Given this list of marker genes CDKN1B, CILP, HNRNPU, PDZK1, MAPK8IP3, KAT6A, PDE5A, DYNC2LI1, CA12, MRNIP, MAP2, CBLN1, GORAB, CACUL1, EPHA5, CCNT2, ZNF396, TMEM68, REEP3, USP6NL, ERG, PIAS1, CPEB2, HOXC6, KDM5B, SHROOM2, ERP27, CES3, BCL11B, SYTL2, KCTD9, TRA2B, LHX2, ACLY, CCNG2, SLC37A2 (NCBI Gene Id 219855), NOVA1, KCTD1, ANXA1, MTCL2, RTN1, MEOX2, AFF4, SRSF12, PALM2AKAP2, RAB4A, NXT2, APBB3, CIP2A, PTPRD, FNDC3B, PIK3CA, SLC25A36, SEPTIN11, ZNF75D, B4GALT4, BRD2, KIF5A, UNC13A, NFIA, CHCHD5, PPP1R16B, ARGLU1, DUSP6, CHD6, ARPP19, RUBCN, ZHX1, MRPL19, MACIR, GABPB1, MCMDC2, CC2D1B, FAM133B, STXBP1, TSG101, CYP2C9, GALNT7, RNF19A (ring finger protein 19A, RBR E3 ubiquitin protein ligase), PAXIP1, FAM13C (family with sequence similarity 13 member C), ZBTB24, STEAP2, CIAO2A, KCTD20, DCUN1D4, RXRG, PPFIA2, EIF2B3, CCNY, FRY, ZNF343, PPP1R18, STAC, CREBBP, DIAPH3, SULF1, TSPAN3, ZNF215, NEK6, ZMIZ1, BAG3, IGFBP5, TRMT10A, AKAP5, JKAMP, GPR12, KLF12, CYP2C8, ARHGEF12, CFAP418, CYP2C18, SERINC5, AFF2, SMC3, KIF20B, FLRT2, PRKD1, NR4A3, here is a description of the gene set: Human Gene Set: MIR4797_5P from publication Chen Y, Wang X (PMID 31504780) Genes predicted to be targets of miRBase v22 microRNA hsa-miR-4797-5p in miRDB v6.0 with MirTarget v4 prediction scores > 80 (high confidence targets). studied in species Homo sapiens